The following is a description of a gene set: Human Gene Set: GOMF_DOPAMINE_BINDING Binding to dopamine, a catecholamine neurotransmitter formed by aromatic-L-amino-acid decarboxylase from 3,4-dihydroxy-L-phenylalanine. studied in species Homo sapiens, and this is the list of marker genes: DRD2, SLC6A3, GPR143, DRD1, DRD4 (dopamine receptor D4), DRD5